The following is a description of a gene set: Genes down-regulated in comparison of LSK versus neutrophils. from publication Konuma T, Nakamura S, Miyagi S, Negishi M, Chiba T, Oguro H, Yuan J, Mochizuki-Kashio M, Ichikawa H, Miyoshi H, Vidal M, Iwama A (PMID 21540074) species: Homo sapiens Each fraction of mouse hematopoietic cells was purified by cell sorting from bone marrow of 8-week-old C57BL/6 mice, and its gene expression was analyzed. Human Gene Set: GSE27786_LSK_VS_NEUTROPHIL_DN, and this is the list of marker genes: MEF2B, SHC1, RRM2B (ribonucleotide reductase regulatory TP53 inducible subunit M2B), PPP2R3C, AK2, TMEM120A, TST, AREL1, AQP9, KCNA7, CFAP119, TRAPPC2, SPACA9, ATG101, RALGAPB, CBLIF, TMEM239, CAST, ZNF236, ZBTB24, LRRC74A, RELB, NFKBIE, BAZ1A, SZT2, MIEN1, PON2, TBC1D10C, SREBF2, MINDY1, UCP2, C9orf78, CCNL2, GPD2, LRP10, CAV3, CMTM6, GSX2, GNAT1, SELENON, PRR14, NHLH1, ZBTB7A, CD4, ACLY, SLC6A5, TRAF3, ALOX12B, TEAD1, GAST (NCBI Gene Id 2520), OST4, PCYT1A, HOPX, BRDT, CCL25, OLFML2A, CHST13, RPP25, GPR107, MALAT1, PTPN9, NBEAL2, FGG, SERPINB1, PPP3R1, TXNDC9, OPN1SW, IFI35, MED11, MED17, C22orf23, VPS28, MAP1LC3B, ELOVL1, KCNK16, ETS1, C14orf119, F2RL2, SRA1, MYH2, LY96, THAP11, TAF13, MFSD14A, ANAPC2, TRIR, FAT3, NECAP2, PARVG, ASB6, CAPZA2, OSBPL7, RECK, TFAP2B, LAD1, BNC2, SLC30A1, ELK1, ARHGEF4, KLHL12, CCDC126, MRAP2, KLHL2, IL36G, RAP1A (NCBI Gene Id 5906), MTMR14, GRN, TEX35, DBH, RAD17, CNR1, C1orf52, MED30, LMAN2L, CARMIL2, MBP, EEPD1, CFAP141, TYR, CYP2A6, MED13L, LAPTM5 (lysosomal protein transmembrane 5), GPANK1, SIRT2, ENPP2, ACTG2, SLC17A9, NAT8, COPA, KDM6B, MAP6D1, VIL1, BICDL2, PCDH8, KLHL6, BECN1, AK5, FBXL19, SFMBT2, NFASC, PRR18, ZIC1, PAQR4, GJA4, IRS2, PTCRA, SUSD6, MOB3A, ARHGAP19, RBP7, HECA, NAALADL1, GPR108, SFT2D2, TLR1, TRIM5, MYO5A, JPH4, ZBP1, ACAP3, MON2, RGCC, FAM217B, SLC44A2, G6PC1, DAAM1, BAIAP3, PFN1, TSTD2, FKBPL, TRAK2, EIF4ENIF1, NDUFA3, PRLR, ZNF414, SLC7A11, BMP15, PHGR1, HSD17B7, KLRG1, STEAP2, KRT6A, PABPC1L, GCNT1, ZCCHC2, CNIH4, KCTD8, NCOA6, DCT, FARP1, OSBPL10, MTMR6 (myotubularin related protein 6), TIAM2, BRSK2, KLRK1, VPS29, PTTG1IP, CHRM3, PTPN12, LAMTOR1